Given this list of marker genes Tgif2, Dag1, Scx, Foxa2, Clasp2, Clasp1, Phldb1, Tgif1 (NCBI Gene Id 21815), Nodal, Crb2, Otx2, Osr2, Hnf4a, Poglut1, Tenm4, Phldb2 (pleckstrin homology like domain, family B, member 2), Lhx1, Osr1, Rack1, here is a description of the gene set: Mouse Gene Set: GOBP_REGULATION_OF_GASTRULATION species: Mus musculus Any process that modulates the rate or extent of gastrulation. Gastrulation is the complex and coordinated series of cellular movements that occurs at the end of cleavage during embryonic development of most animals.